The following is a description of a gene set: The chemical reactions and pathways resulting in the formation of a polysaccharide, a polymer of many (typically more than 10) monosaccharide residues linked glycosidically. Human Gene Set: GOBP_POLYSACCHARIDE_BIOSYNTHETIC_PROCESS species: Homo sapiens, and this is the list of marker genes: INPP5K, ACADM, IGF1, UGP2, INSR, PPP1R3B, GCK, PPP1R3G, HAS1, SORBS1, MIR1271, AGL, MIR15B, AP2A1, GYS1, NDST1, IRS2, PPP1R3C, AKT1, PTH, AKT2, EPM2A, SELENOS, PPP1R3F, PPP1R3A, PRKAG3, EGF, GYG1, GRB10, EPM2AIP1, HAS2, IRS1 (insulin receptor substrate 1), INS, IGF2, TGFB1, MIR195, SMPD3, PPP1R3D, NR1D1, CLTC, GYG2 (NCBI Gene Id 8908, glycogenin 2), PDGFB, GSK3A, FUT9, DYRK2, ENPP1, PPP1R3E, EXT1, PGM2, NFKB1, EXT2, NHLRC1, PER2, GYS2, GSK3B, PASK, PPP1CA, HAS3 (hyaluronan synthase 3), GBE1